Given this list of marker genes Abraxas2, Becn1, Spc24, Racgap1, Sirt2, Birc5, Champ1, Knstrn, Kat2b, Ska2, Rcc2, Ccnb1, Cdca8 (NCBI Gene Id 68105), Ska1, Eml4, Cenpc1, Ndc80 (NDC80 kinetochore complex component), Nsl1, Arhgap33os, Aurkb, Ska3, Abraxas1, Bub3, Pmf1, Spc25, Snhg15 (NCBI Gene Id 100041286), Kif2c, Tex14, Cenpe, Sirt1, Mis12, Seh1l, Knl1, Ect2, Mapre1, Cdt1, Rb1, Dsn1, Sgo1, Cdk1, Mad1l1 (NCBI Gene Id 17120), Hnrnpu, Nek2, Spag5, Cdc42, Incenp, Ccnb1-ps, Kat5, Zfp207, Nuf2, Apc, here is a description of the gene set: Mouse Gene Set: GOBP_ATTACHMENT_OF_SPINDLE_MICROTUBULES_TO_KINETOCHORE The process in which spindle microtubules become physically associated with the proteins making up the kinetochore complex. studied in species Mus musculus